Given this list of marker genes Map9, Csde1, Gabarapl2, Adamtsl4, Dspp, Trpc4ap, Gmeb1, Ubd, Trmt44, Jade1, Adra2b, Mief1, Igsf3, Gnpda1, Srpk2 (NCBI Gene Id 22382), Mfsd3, Pcsk7, Hspa4, Ipcef1, Dcdc2c, Tmem33, Kctd4, Ube3a, Gmps, Mcts2, Glra2, Tomm34, Asrgl1, Cpeb1, Adamtsl5 (ADAMTS-like 5), Naip5, Trmt2b, Il2ra, Srsf7, Hyal6, Acad8, Chst8, Armc8, Tet2, Fbn2, 1700018B08Rik, Sgpp1, Ifih1, Synm, Nos1, Lpp, Tmco3, Nfe2l2, Bltp3a, Pvr (NCBI Gene Id 70704), Homer1, Ints8, Pom121, Cxcl14, Gabpa, Tapt1, Nr1h4, Pnma2, Abce1, Map3k9, Fras1, Polr2l, Ano10, Smarca5, Rnf214, Tyw1, Ppargc1a, Slmap, Iqsec1, Slc5a7, Ranbp17, Hif3a, Tasp1, Zzz3, Sox7, Coro1c, Smarcc1, Triml1, Fam228b, Ephb2, Alg11, Phip, Nipa2, Stard7, AU018091, Cyb5d2, here is a description of the gene set: Genes predicted to be targets of miRBase v22 microRNA mmu_miR_5112 in miRDB v6.0 with MirTarget v4 prediction scores > 80 (high confidence targets). species: Mus musculus Mouse Gene Set: MIR_5112 from publication Chen Y, Wang X (PMID 31504780)